Given this list of marker genes NEFL, DAB1, RNU4-2, SET, DMD, ORAI1, LRAT, TPM2, FXN, PTS, GNB2, TTN, CHD2, MAPK10, ALDH18A1, VPS13A, SACS (sacsin molecular chaperone), SPTBN1, SDHB (succinate dehydrogenase complex iron sulfur subunit B), CACNA1A, PRKAR1B, GABRB3, POPDC3, SCN1A, PDE2A, NDUFS8, ATP6AP2, FA2H, MAPT, ACBD5, CUX2 (NCBI Gene Id 23316), DNM1, CERS1, ATP13A2, OGDH, NKX2-1, MYH7, DNA2, GAN, VPS13C, SLC25A21, RAPSN, here is a description of the gene set: species: Homo sapiens Falls Human Gene Set: HP_FALLS